The following is a description of a gene set: studied in species Homo sapiens Autophagy-vesicle nucleation/elongation/maturation, PACER-RUBCN-PI3KC3-C2. Pathway ID: N01718. Pathway type: Reference. Pathway class: nt06532 Autophagy. Pathway Definition from KEGG: RUBCNL -| RUBCN -| PI3KC3-C2 Human Gene Set: KEGG_MEDICUS_REFERENCE_AUTOPHAGY_VESICLE_NUCLEATION_ELONGATION_MATURATION_PACER_RUBCN_PI3KC3_C2, and this is the list of marker genes: PIK3R4, NRBF2, RUBCNL, BECN1, UVRAG, RUBCN, PIK3C3